The following is a description of a gene set: Previous microarray studies on breast cancer identified multiple tumour classes, of which the most prominent, named luminal and basal, differ in expression of the oestrogen receptor alpha gene (ER). We report here the identification of a group of breast tumours with increased androgen signalling and a 'molecular apocrine' gene expression profile. Tumour samples from 49 patients with large operable or locally advanced breast cancers were tested on Affymetrix U133A gene expression microarrays. Principal components analysis and hierarchical clustering split the tumours into three groups: basal, luminal and a group we call molecular apocrine. All of the molecular apocrine tumours have strong apocrine features on histological examination (P=0.0002). The molecular apocrine group is androgen receptor (AR) positive and contains all of the ER-negative tumours outside the basal group. Kolmogorov-Smirnov testing indicates that oestrogen signalling is most active in the luminal group, and androgen signalling is most active in the molecular apocrine group. ERBB2 amplification is commoner in the molecular apocrine than the other groups. Genes that best split the three groups were identified by Wilcoxon test. Correlation of the average expression profile of these genes in our data with the expression profile of individual tumours in four published breast cancer studies suggest that molecular apocrine tumours represent 8-14% of tumours in these studies. Our data show that it is possible with microarray data to divide mammary tumour cells into three groups based on steroid receptor activity: luminal (ER+ AR+), basal (ER- AR-) and molecular apocrine (ER- AR+). from publication Farmer P, Bonnefoi H, Becette V, Tubiana-Hulin M, Fumoleau P, Larsimont D, Macgrogan G, Bergh J, Cameron D, Goldstein D, Duss S, Nicoulaz AL, Brisken C, Fiche M, Delorenzi M, Iggo R (PMID 15897907) Human Gene Set: FARMER_BREAST_CANCER_CLUSTER_6 Cluster 6: selected luminal genes clustered together across breast cancer samples. species: Homo sapiens, and this is the list of marker genes: SLC39A6, ESR1, RBM47, KIAA0232 (NCBI Gene Id 9778, KIAA0232), TBC1D9, MLPH, REEP5, TSPAN13, CERS6, TTC39A, AGR2, GATA3, RHOB, GPD1L